Given this list of marker genes ZIC2, SLC18A2, GLI2, NODAL, MAGEL2, SLC25A19, FCGR3B, FOXH1, CDON, MKRN3, GAS1, MYO1H, SPR, STIL, DLL1, PWAR1, TGIF1, PTCH1, FGF8, PSAP, LMNB1, STAG2, FGFR1, VPS11, SHH, DDC, ALG11, GALC (galactosylceramidase), SNORD115-1, SHQ1, SLC31A1, SIX3 (SIX homeobox 3), PLCH1, NPAP1, PLA2G6 (NCBI Gene Id 8398), PWRN1, SNORD116-1, DISP1, HERC2, CRIPTO, SMC1A, here is a description of the gene set: Temperature instability studied in species Homo sapiens Human Gene Set: HP_TEMPERATURE_INSTABILITY Disordered thermoregulation characterized by an impaired ability to maintain a balance between heat production and heat loss, with resulting instability of body temperature.